Given this list of marker genes CCND1, SLFN5, TMEM14A, ANPEP, RAB3D (RAB3D, member RAS oncogene family), TCP11L1, XKRX, RPA3, HMOX1, AP1S3, PHF1, TACO1, CD63, TEDC1, STARD5, LIPE, MS4A7, LCN8, FCER1G, GRK3, CALHM2, STON2, RETSAT, RNF13, GDI2, CD300A, IGSF8, CP, CYB561A3, GDPGP1, CX3CR1, TLN1, CAT, C6orf47, ITGA4, MAPK13, IL5, CASS4, SETMAR, P2RY6, SNX27, ATOX1, CALHM6, SLC8A1, UBL7, GDF11, INKA1, CBX7, KIAA0513, IFIT1, PAGR1, PYCARD, SHLD1, DPYSL2, HHEX (NCBI Gene Id 5556), EXTL2, CXCR2, PRKD2 (protein kinase D2), PLA2G15, ANGPTL1, PLXNA1, CNN2, STARD8, S100A8, PLCD1, DNMT1, RHBDF2, H6PD, SLCO2B1, CSF3R, MCL1, CFAP410, CD55, IL15RA, LILRB3, CCDC167, TRIM56, DDX17, C16orf54, CFH, CYFIP1, IRF2, DCST1, ARHGAP45, GBGT1, MERTK, NCKAP1L, SNX32, ASB2, NTPCR, MAGEA6, PXDC1, VAMP5, CSF2RB (NCBI Gene Id 3564), OOSP1 (NCBI Gene Id 255649), UBA3, SERPINB10, KLHL5, SLC26A6, SIRT6, FBXL14, SPINT1, CCDC61, ABCA6, FAM193B, PML, MMP9, IL18, CD7, EVL, XIST, PHF7, FMNL1, NAA60, MT-CYB, SUSD3, ADGRE4P (NCBI Gene Id 347749), CYB561D2, LILRA5, MRPL40, STING1, SGIP1 (SH3GL interacting endocytic adaptor 1), RDH12, KLHL42, ERLEC1, ROPN1L, GIMAP8, CTSC, PYM1, PPEF2, GLO1, MFAP3, CIITA, BABAM1, FBXL8, HTATIP2, PLEKHA4, SULF2, LY6S, MFHAS1, ADGRG5, HGS, DTD2, TREML4, TWF2, NFE2, MYO1F (NCBI Gene Id 4542), METRN, here is a description of the gene set: The transcription factor FoxP3 partakes dominantly in the specification and function of FoxP3+ CD4+ T regulatory cells (Tregs), but is neither strictly necessary nor sufficient to determine the characteristic Treg transcriptional signature. Computational network inference and experimental testing assessed the contribution of several other transcription factors (TFs). Enforced expression of Helios or Xbp1 elicited specific signatures, but Eos, Irf4, Satb1, Lef1 and Gata1 elicited exactly the same outcome, synergizing with FoxP3 to activate most of the Treg signature, including key TFs, and enhancing FoxP3 occupancy at its genomic targets. Conversely, the Treg signature was robust to inactivation of any single cofactor. A redundant genetic switch thus locks-in the Treg phenotype, a model which accounts for several aspects of Treg physiology, differentiation and stability. species: Homo sapiens from publication Fu W, Ergun A, Lu T, Hill JA, Haxhinasto S, Fassett MS, Gazit R, Adoro S, Glimcher L, Chan S, Kastner P, Rossi D, Collins JJ, Mathis D, Benoist C (PMID 22961053) Human Gene Set: GSE40274_CTRL_VS_GATA1_TRANSDUCED_ACTIVATED_CD4_TCELL_UP Genes up-regulated in CD4 T conv: control versus over-expression of GATA1.